The following is a description of a gene set: Human Gene Set: GSE45365_NK_CELL_VS_BCELL_UP species: Homo sapiens Genes up-regulated in NK cells versus B lymphocytes. Murine Cytomegalovirus (MCMV) infection leads to early activation of various immune cells, including B and T lymphocytes, before the actual initiation of antigen-specific adaptive immunity. This activation is partly driven by innate cytokines, including type I interferon (IFN), which are induced early after infection. The objective of this study was to address the role of type I IFN in shaping early/innate B and T cell responses to a primary acute viral infection. In order to decipher the specific impact of IFN-I on cell subsets, we performed a genome-wide expression analysis on WT splenic B and CD8 T lymphocytes isolated from C57BL/6 mixed bone marrow chimera mice. This study complements series GSE39555, which focused on early responses of NK cells and of the two subsets of conventional dendritic cells., and this is the list of marker genes: SELP, GRAMD2B, UTP18, ATP2A2, NSUN2, ATF6, GALNT4, CH25H, HSP90AA1 (heat shock protein 90 alpha family class A member 1), ID3, SERPINE1, CCN1, THBS1, ARC, CCL13, VCAM1, PICALM, NUFIP1, ATP6V1H, WRNIP1, TMTC2, SF3B3, SLC25A32, SLBP, CA13, CPNE8, JUNB, PTGES, ENC1, FAM43A, SLC7A1 (solute carrier family 7 member 1), SPTY2D1, MLX, ICAM1, ZFP36, IER5, DCBLD2, RGS2, BCL10, C19orf33, MAPK6, GAK, B3GNT2, BCAT1, NIFK, NFYA, SOCS5, MBOAT1, TMEM128, NABP1 (nucleic acid binding protein 1), RNF138, IFNAR1, SNHG12, NDEL1, PPP1R15B, SLC30A4, IFRD1, SIAH2, TCIM, CASS4, MOB3A, CRLF3, MAP3K5, H6PD, PAK2, DIDO1, FOSL1, WDR3 (NCBI Gene Id 10885), POLR3E, FGL2, HNRNPH1, PCNA (NCBI Gene Id 5111), EPB41L4A, SLC39A6, FEM1B, ARID5B, SLC7A6OS, SDE2, PHLDA1, HAS1, AGGF1 (angiogenic factor with G-patch and FHA domains 1), CLPTM1L, GEM, RBM12 (NCBI Gene Id 56682), TBK1, ARF4, CTDP1, P2RY10, DUSP6, CAD, GNL3, MID1IP1, DNAJA1 (DnaJ heat shock protein family (Hsp40) member A1), ERAP1, TASOR2, EDEM1, PAFAH1B2, THBD, MCUB, MFSD14B, RBMXL1, CXCL3, JAK2, MAT2A, RRAD, JDP2, C11orf24, RIOX1, BAZ2B, TSR1, LIF, MANF, EGR1, RAP1B, CBL, STX19, RELA, USP36, RNF19B, DUSP1, DOCK10, NFKBID, BIRC3, CSRNP1 (cysteine and serine rich nuclear protein 1), SLC39A10, IL6ST, EGR3, SPP1, UTP20, CDH11, YWHAZ, SIGMAR1, AMPD3, ZNF236, SH3BP2, WDR1, ZDHHC5, FOS, BDP1, SLC23A2, CYP7B1, XPNPEP1, ST8SIA4, BACH1, STX12, TNFAIP6, VASP, SLC7A5, TMEM87B, GNG12, MDN1, CD83, ATP6V1A, ABHD17C, CHSY1, ARL5B, HAS3, CASP8, ALG11, CHIC2, WWTR1, AGFG1, ARHGAP8, ASS1, ZNF655, GCC1, RND1, CDK9 (NCBI Gene Id 1025), RHOD (ras homolog family member D), PACRGL, RLIM, SLC2A1, CBR3 (NCBI Gene Id 874), MON2, SLCO2A1, ATF3, PKIB, METTL9, TTPAL, NOP56, S100A8 (NCBI Gene Id 6279), LDLR, SNORD89, NCBP1, FBL, CRELD2, IER2, IL6, CAPN2, TNFAIP3, ESYT2, OSGIN2, ABL2, WDR75, FOSB, ZC3HAV1, SRSF9, MYEF2